Given this list of marker genes Ago4, Tnrc6c, here is a description of the gene set: Reactome Pathway: Post-transcriptional silencing by small RNAs species: Mus musculus part of: Gene Silencing by RNA This event has been computationally inferred from an event that has been demonstrated in another species.<p>The inference is based on the homology mapping from PANTHER. Briefly, reactions for which all involved PhysicalEntities (in input, output and catalyst) have a mapped orthologue/paralogue (for complexes at least 75% of components must have a mapping) are inferred to the other species. electronically inferred by orthology from the curated human pathway